The following is a description of a gene set: The cellular synthesis of messenger RNA (mRNA) from a DNA template. species: Homo sapiens Human Gene Set: GOBP_MRNA_TRANSCRIPTION, and this is the list of marker genes: RARA, MED1, STAT3 (NCBI Gene Id 6774), TAF1, TAF12, ATF2, CREB1, TAF6, TAF4, TAF8, TFCP2, NCBP3, TAF5, DDX5, NR1H3, ZIC3, NCOA2, ATF4, TAF2, FOXE3, C5AR1, NCBP1, TBP, RXRB, HLTF, TAF10, TP53, RXRA, VDR, TAF9, AP3B1, THRA, TAF13, HIPK3, IRF3, EPAS1, TAF7, NCBP2, TAF3, NFKBIZ, NCOA1, THRB, ZBTB1, FLNA, ANXA2, TAF11, EREG, TAF4B, S100A10, NR1H2, PPARG, SREBF1